The following is a description of a gene set: Genes down-regulated in monocytes treated by rosiglitazone: Ly6C high versus Ly6C low. PPARγ is known for its anti-inflammatory actions in macrophages. However, which macrophage populations express PPARγ in vivo and how it regulates tissue homeostasis in the steady state and during inflammation is not completely understood. We show that lung and spleen macrophages constitutively expressed PPARγ, while other macrophage populations did not. Recruitment of monocytes to sites of inflammation was associated with induction of PPARγ as they differentiated to macrophages. Its absence in these macrophages led to failed resolution of inflammation, characterized by persistent, low-level recruitment of leukocytes. Conversely, PPARγ agonists supported an earlier cessation in leukocyte recruitment during resolution of acute inflammation and likewise suppressed monocyte recruitment to chronically inflamed atherosclerotic vessels. In the steady state, PPARγ deficiency in macrophages had no obvious impact in the spleen but profoundly altered cellular lipid homeostasis in lung macrophages. Reminiscent of pulmonary alveolar proteinosis, LysM-Cre x PPARγflox/flox mice displayed mild leukocytic inflammation in the steady-state lung and succumbed faster to mortality upon infection with S. pneumoniae. Surprisingly, this mortality was not due to overly exuberant inflammation, but instead to impaired bacterial clearance. Thus, in addition to its anti-inflammatory role in promoting resolution of inflammation, PPARγ sustains functionality in lung macrophages and thereby has a pivotal role in supporting pulmonary host defense. from publication Gautier EL, Chow A, Spanbroek R, Marcelin G, Greter M, Jakubzick C, Bogunovic M, Leboeuf M, van Rooijen N, Habenicht AJ, Merad M, Randolph GJ (PMID 22855714) studied in species Homo sapiens Human Gene Set: GSE32034_LY6C_HIGH_VS_LOW_ROSIGLIZATONE_TREATED_MONOCYTE_DN, and this is the list of marker genes: ABCF2, CYB5R3, DLX2, JAK3, NDRG4, EMP1, ACOD1, RAB21, INTS8, CASP6, DDR1, RNASE1, HNRNPC, CEBPD, TIPARP, MAP2K4, SLC12A1, RHOT1, EYA3, PPRC1, ANPEP, NOCT, LARGE1, DAPK3, CCL7, TMPRSS15, CHI3L1, AGFG1, PIK3C2A, TXNRD1, DPEP1, RASAL1, CORO2B, UNC13B (NCBI Gene Id 10497), ERRFI1, SLC2A1, CAND1, JUN, SOAT1, LPAR1, ZFP36, MCOLN2, RGS16, B4GALT3, ERLIN1, VCAN, PTPN1, ST3GAL4, CASP4, EXTL3, FBXL12, PTGER4, IL17RA, ITGA5, P2RY2, C9orf85, BCL3, RNH1, CCL2, IKZF1, CITED2, CCL4, ARG2, HYOU1, TUBA4A, ZBTB2, CXCR3, TRPC1, NEDD4L, SLC12A7, GSR, ID1, ENO1, VAX1, U2SURP, MAPK6, OCEL1, HIF1A, SRA1, CLDND1, TGFB1, STOM, APLP1, CD180, SRGN, RBMS1, RAB4B, RTL6, CDKN2D, RPL31, CH25H, CCL13, EQTN, EIF1AY, COQ4, IFITM3, PTPN11, GALNT6, PRKCH, CA8, ACOT9, ADORA2B (NCBI Gene Id 136), CD164, UGCG, MED1, TCAP, GAB1, LYST, PIGR, TEC, OR2H2, CD86, DNAJC5, CKB, CTSE, IRF1, HMOX1, CXCL10, MAP3K8, SUSD6, GADD45G, SPTA1, PDIA4, EHD1 (NCBI Gene Id 10938), BAG6, COL19A1, GCH1, IGLL1, TIMP1, PPIF, ST6GALNAC4, NFKBIZ, TSKU, TACR1, CD244, DIAPH2, ABCD3, RHBDL3 (NCBI Gene Id 162494), KCNQ1, JAK2 (Janus kinase 2), SCIN, NOC4L, IL13RA1, NR3C1, JUNB, SNRK, CXCL6, TADA1, AFF1, PLSCR1, IL2RG, ST3GAL6, SOCS1, IFI30, TARS2, KARS1, NDRG1 (N-myc downstream regulated 1), KCNK1, PIM1 (NCBI Gene Id 82453), DNAAF10, GNAQ, UBQLN1, MATN2, LIN7B, SFTPD, GUCA1A, SPTAN1, CFHR1, SOAT2, GZMK, SHISA5, CD59, IL17D, CD99, SALL3, PSMC1, ITIH3, PCGF5, LGALS8, DNTT, ST3GAL5, LAMB3, BACH1, ETS2, PVT1, GATAD2A, CPXM1, MIDN, GCLM, ZNF281, CCR1, ZFAND5, FCGR2B, TNFSF9, TBR1, PCSK2, RSRC2, CLCN7, NAB1, KRT77